The following is a description of a gene set: electronically inferred by orthology from the curated human pathway studied in species Mus musculus part of: Hemostasis Reactome Pathway: Coagulation pathway This event has been computationally inferred from an event that has been demonstrated in another species.<p>The inference is based on the homology mapping from PANTHER. Briefly, reactions for which all involved PhysicalEntities (in input, output and catalyst) have a mapped orthologue/paralogue (for complexes at least 75% of components must have a mapping) are inferred to the other species., and this is the list of marker genes: Pros1, Prtn3, Kng2, Gp1ba, Gp1bb, Serpind1 (serine (or cysteine) peptidase inhibitor, clade D, member 1), F7, Gpc3, Fgg, Serping1, Serpine2, F2 (NCBI Gene Id 14061), Proz, F10, Serpina10, Pf4, F13b, F8, Itga2b, F9, Adamts13, Cd177, F12, Smpd1, Gp9, Serpina5, Gpc2, F13a1 (coagulation factor XIII, A1 subunit), Proc, Sdc3, Sdc1, Ano5, Klkb1